Given this list of marker genes NKIRAS1, RALGPS1, RALGAPA2, RALGAPB, NKIRAS2, RGL2, here is a description of the gene set: Human Gene Set: GOBP_RAL_PROTEIN_SIGNAL_TRANSDUCTION An intracellular signaling cassette in which a small monomeric GTPase of the RaI subfamily relays a signal. studied in species Homo sapiens